The following is a description of a gene set: Catalysis of an oxidation-reduction (redox) reaction in which a nitrogenous group, excluding NH and NH2 groups, acts as a hydrogen or electron donor and reduces a cytochrome. species: Mus musculus Mouse Gene Set: GOMF_OXIDOREDUCTASE_ACTIVITY_ACTING_ON_OTHER_NITROGENOUS_COMPOUNDS_AS_DONORS_CYTOCHROME_AS_ACCEPTOR, and this is the list of marker genes: Mtarc1, Xdh, Cyb5b (cytochrome b5 type B), Cbs, Cyb5r3, Cyp1a2